Given this list of marker genes Mtarc1, Xdh, Aox1, Gphn, Aox3, Suox, Aox4, Mtarc2, Aox2, here is a description of the gene set: Mouse Gene Set: GOMF_MOLYBDOPTERIN_COFACTOR_BINDING studied in species Mus musculus Binding to a molybdopterin cofactor (Moco), essential for the catalytic activity of some enzymes, e.g. sulfite oxidase, xanthine dehydrogenase, and aldehyde oxidase. The cofactor consists of a mononuclear molybdenum (Mo-molybdopterin) or tungsten ion (W-molybdopterin) coordinated by one or two molybdopterin ligands.